The following is a description of a gene set: studied in species Homo sapiens Human Gene Set: GOBP_REGULATION_OF_PROTEIN_EXPORT_FROM_NUCLEUS Any process that modulates the frequency, rate or extent of the directed movement of proteins from the nucleus to the cytoplasm., and this is the list of marker genes: BAG3, YWHAE, GSK3B (NCBI Gene Id 2932), PRKD1, PRP4K, TPR, IFI27, IL1B (interleukin 1 beta), CTDSPL2, BARD1, UHMK1, SIRT6, PPM1A, XPO4 (NCBI Gene Id 64328), FRAT1, TXN, PRKACA, FRAT2, CDK5, FAM76B, PARK7, MDM2, SP100, CDKN2A, SFN, CAMK1, RAPGEF3, RBM22, ANP32B, PTPN14, XPO1, SIRT7, HDAC3, EMD, PTPN11, GAS6, RANGAP1